The following is a description of a gene set: Human Gene Set: GOCC_PERICHROMATIN_FIBRILS studied in species Homo sapiens Structures of variable diameter visible in the nucleoplasm by electron microscopy, mainly observed near the border of condensed chromatin. The fibrils are enriched in RNA, and are believed to be sites of pre-mRNA splicing and polyadenylylation representing the in situ form of nascent transcripts., and this is the list of marker genes: CPSF6, NUFIP1, TRIM24, TARDBP, DHX9